Given this list of marker genes HLA-E, UL83, IGHV2-5, ICAM4, IGKV1D-16, ULBP3, IGLV8-61, LAIR2, IGKV4-1, LILRA4, CD96, CLEC2B, PVR, ITGB2, TRBV12-3, HN, CD8A, IGKV1-17, IGLV11-55, IGKV2-28, CD1D, FCGR3A, IGKV3D-20, KLRG1, IGLV4-60, IGLC1, IGHV3-33 (NCBI Gene Id 28434), HLA-F (NCBI Gene Id 3134), IGHV, IGHV3-9, TRAC, CD300LD, CD40, SIGLEC7, IGLV6-57, TRAV29DV5 (T cell receptor alpha variable 29/delta variable 5), IGLC7, IGKV5-2, CD99, CRTAM, CD81, SH2D1B, LAIR1, CD1B, IGHV4-59, COL1A1, PIANP, HA, IGHV7-81, ITGB7, KLRC1, IGHV3-30, KLRF1, IGLC6, IGLV1-51, HLA-B, IGLV2-33, TRBV7-9, IGKV1D-33, IGLV3-19, SIGLEC9, KIR2DL4, VCAM1, KIR2DL1, ICAM1, IGKV3-15, IGLV3-21, SIGLEC10, SIGLEC12, TREML1, KLRD1, IGLC3, IGLV10-54, KIR2DL3, SFTPD, CD200, COL1A2, HLA-A, IGLV7-46, IGHV1-46, IGLV3-12, IGKV2D-28, IGLV7-43, CD19, NCR2, NPDC1, TREML2, IGLV5-37, IGHV1-2, IGHV1-69, HLA-G, PILRA, LILRB1, LILRB4, IGKV1D-12, LILRA1, IGLV2-8, SIGLEC5, CD300LB, IGLV5-45, NCR3LG1, IGKV1-16, MADCAM1 (NCBI Gene Id 8174), CXADR, TRAV19, GLYCAM1, ITGA4 (integrin subunit alpha 4), OSCAR, CD300LF, IGHV3-7, IFITM1, cd21, IGKV2-30, TREML4, KIR2DL2, KIR3DL2, LILRB3, TRAV8-4, KLRK1, KIR2DS2, IGHV3-13, IGKV2D-30, CD3E, CLEC2D, JAML, IGLV2-14, CD22, LILRA6, IGKV3-20, LILRB2, LILRA2, IGLV1-44 (immunoglobulin lambda variable 1-44, NCBI Gene Id 28823), SIGLEC8, COL17A1, ICAM3, ICAM5, IGHV3-23, IGLV4-69, KIR3DL1, LILRA5, COLEC12, CD200R1, SIGLEC1, IGHV4-39, ITGAL, ICAM2, IGHV3-11, IGHV4-34, IGLV4-3, ITGB1, HLA-H, IGLV1-36, CD1A, TYROBP, FCGR2B, FCGR1A, B2M, IGLV1-40, IGKV1-39, TREM1, IGLV2-18, NCR1, HLA-C, COL2A1, SIGLEC6, IGKV1D-39, IGKV2-29, IGKC, CD40LG, IGKV1-33, SIGLEC11 (sialic acid binding Ig like lectin 11), CD1C, IGHV3-53, ULBP1, IGLV3-25, CD34, IGKV1-12, SLAMF7, IGKV1-5, CD300C, MICB, IGHV3-48, SH2D1A, CD226, KIR2DS1, TREM2 (NCBI Gene Id 54209), C3, CD300LG, CD247, IGLV2-11, NECTIN2 (NCBI Gene Id 5819), IGLV1-47, PILRB, IGLV3-1, CD300A, CD33, LILRA3, NCR3, IGHV2-70, CD8B, IGLV3-22, TRBC1, KLRB1, CD160, HCST, IGLV2-23, IGLV3-27, IGKV3-11, CD3D, CD300E, SLAMF6, RAET1E, IGLC2, CDH1, IGLV, LILRB5, CLEC4G, SELL, MICA, COL3A1, IGKV2D-40, IGLV3-16, CD3G, here is a description of the gene set: Reactome Pathway: Immunoregulatory interactions between a Lymphoid and a non-Lymphoid cell part of: Adaptive Immune System studied in species Homo sapiens A number of receptors and cell adhesion molecules play a key role in modifying the response of cells of lymphoid origin (such as B-, T- and NK cells) to self and tumor antigens, as well as to pathogenic organisms.<p><p>Molecules such as KIRs and LILRs form part of a crucial surveillance system that looks out for any derangement, usually caused by cancer or viral infection, in MHC Class I presentation. Somatic cells are also able to report internal functional impairment by displaying surface stress markers such as MICA. The presence of these molecules on somatic cells is picked up by C-lectin NK immune receptors.<p><p>Lymphoid cells are able to regulate their location and movement in accordance to their state of activation, and home in on tissues expressing the appropriate complementary ligands. For example, lymphoid cells may fine tune the presence and concentration of adhesion molecules belonging to the IgSF, Selectin and Integrin class that interact with a number of vascular markers of inflammation.<p><p>Furthermore, there are a number of avenues through which lymphoid cells may interact with antigen. This may be presented directly to a specific T-cell receptor in the context of an MHC molecule. Antigen-antibody complexes may anchor to the cell via a small number of lymphoid-specific Fc receptors that may, in turn, influence cell function further. Activated complement factor C3d binds to both antigen and to cell surface receptor CD21. In such cases, the far-reaching influence of CD19 on B-lymphocyte function is tempered by its interaction with CD21.